The following is a description of a gene set: from publication Fazilleau N, Eisenbraun MD, Malherbe L, Ebright JN, Pogue-Caley RR, McHeyzer-Williams LJ, McHeyzer-Williams MG (PMID 17529982) Mice were immunized with PCC (pigeon cytochrome c). Genes down-regulated in CD4 T cells from lymph nodes: naïve versus day 7 after immunization. species: Homo sapiens Human Gene Set: GSE7548_NAIVE_VS_DAY7_PCC_IMMUNIZATION_CD4_TCELL_DN, and this is the list of marker genes: RBM4, ADGRE5, LMNB1, AMOTL2, FLOT1, CD47, SSTR2, OASL, PGAP1, SP100, TLK2, ETS2, APOBEC3G, IFITM1, TRPC4AP, RP2, ARID5A, BST2, CD69, OGFR, ST3GAL5, SSB, VAMP5, TNPO1, PRKAB1, PSMA2, RIN2, WARS1, SETX, OAS2, HIVEP2, IFIT5, CCL8 (C-C motif chemokine ligand 8), GTF2B, TSC22D1, SASH1, ELF4, IFI16, NUP153 (nucleoporin 153), LAG3, UBE2S, DUSP5, DHX15, PFKP, SPTA1, CMTR1, GART, SHOC2, BRCA2, ARL4A (NCBI Gene Id 10124), XAF1, BARD1, RSAD2 (NCBI Gene Id 91543), RGL1, TENT4A, CXCL10, NASP, LYN, CLDND1, CXCL9, SRGAP2, IFITM2, KIAA0040, CBR1, GBP1, MAMLD1, GCH1, HPRT1, NMI, MICB, ABTB2, MX2, ADAR, TESK1, DEFB1, SLC30A1, BLTP1 (bridge-like lipid transfer protein family member 1), PCMT1, OAS1, RBMS1, RAB5A, CFH, IGF2R, TERF2IP, SP110, EFR3A, TIA1, SRSF4, PDGFRL, CHSY1 (NCBI Gene Id 22856), GMPR (NCBI Gene Id 2766), TGM1, CXCL11, RALB, GCNT1, HEG1, PSMA3, ISG20 (NCBI Gene Id 3669), MX1, NPC1, IL15RA, IFITM3, MVP, NXF1, RIPK1, CDK17 (cyclin dependent kinase 17), IFIT1 (interferon induced protein with tetratricopeptide repeats 1), KLF6, MNDA, UBA7, ENPP2, CMKLR1, BAZ1A, H3-3B, PPP2R2A, IL3RA, RAPGEF2, TRIM26, IFIT2, IFI27, MT2A, TRAFD1, HIRA, IL10RA, TFEC, ZFP36, ISG15, PML, FUT4, SERPINB1, RAD9A, ATF5, TRIM22, BAK1, ATF6, RIF1, STK3, CASP7, KARS1, NFE2L3, CKS1B, MFN1, ARNT2, MYL12A, DYNLT1, SAMD4A, CD2AP, CASP10, IFIT3, IGFBP4, FAS, PTK2B, BAG1, PAF1, EXT2, IDO1, PLSCR1, SMAD3, SFT2D2, MDK, STK17B, PRKCD, C6orf62, N4BP1, CD1D, MALT1, LAMP3, RNF19B, TOP1, IFI44, P2RY14, IRF7, NBN, RUBCN, IFI35, TRIM21, SEPTIN4, TAP1, IFI44L, RTCB, BIRC2, SEC23B, ASIP, TDRD7, DNAJA1, APOL1, CSF2RB, IER2, CASP5, CSRNP2, ADM, RABGAP1L, RBCK1, THOC2, SOCS1, TOR1B, ZC3HAV1, TMEM87A, GCA